The following is a description of a gene set: Genes down-regulated in splenocytes: control versus infected with Baki-1 MuLV virus. Human Gene Set: GSE24671_CTRL_VS_BAKIMULC_INFECTED_MOUSE_SPLENOCYTES_DN studied in species Homo sapiens from publication Yu P, Lübben W, Slomka H, Gebler J, Konert M, Cai C, Neubrandt L, Prazeres da Costa O, Paul S, Dehnert S, Döhne K, Thanisch M, Storsberg S, Wiegand L, Kaufmann A, Nain M, Quintanilla-Martinez L, Bettio S, Schnierle B, Kolesnikova L, Becker S, Schnare M, Bauer S (PMID 23142781) The genome of vertebrates contains endogenous retroviruses (ERVs) that have resulted from ancestral infections by exogenous retroviruses. ERVs are germline encoded, transmitted in a Mendelian fashion and account for about 8% of the human and 9.9% of the murine genome, respectively1, 2. By spontaneous activation and reintegration ERVs may cause insertional mutagenesis and thus participate in the process of malignant transformation or progression of tumor growth3, 4. However, if the innate immune system is able to recognize and control ERVs has not yet been elucidated. Here we report that, in vitro, nucleic-acid sensing TLRs on dendritic cells are activated by retroviral RNA and DNA from infected cells in vitro. Infection of TLR competent wild type mice with murine leukemia virus (MuLV)-like ERV isolates results in non-canonical gene upregulation, independent of type I IFN. In vivo, TLR3, -7 and -9 triple deficient mice (TLR379-/-) and mice with non functional TLR3, 7 and 9 signaling due to a mutation in UNC93B develop spontaneous ERV-induced viremia. More importantly, in TLR379-/- mice ERV-induced viremia correlates with acute T cell lymphoblastic leukemia (T-ALL). Multiple independent TLR379-/- T cell leukemia lines produce infectious MuLV of endogenous origin. These cell lines display de novo retroviral integration into the Nup214 or Notch1 gene locus leading to gene dysregulation that is reminiscent of aberrant Nup214 and Notch1 expression in human T-ALLs5. Overall, our results demonstrate that in addition to their role in innate immune defense against exogenous pathogens, TLR3,-7, and -9 may be essential for the control of endogenous retroviral mediated T-cell lymphomagenesis., and this is the list of marker genes: ZC3HAV1, VPS37B, TSC22D2, RPS3, TTC16, HS3ST1, SEMA4A, RPL13, PLCD1, NFKBIA, KRT19, INPP4B, KLRG1, CD69, VBP1, PRNP, AMPH, NR4A1, RPL32, GJA1, ZCCHC14, CACNB1, EPAS1 (NCBI Gene Id 2034), SIK1 (NCBI Gene Id 54018), COL5A2, THSD4, PITPNC1, DUSP6, CRYBG1 (crystallin beta-gamma domain containing 1), RBPJ, AREG, FIGNL2, ZCCHC10, FBXL21P, MYOCD (myocardin), RPS26, AFAP1L1, LPCAT2, TNFAIP3, GAR1, FSTL1, SLC18A2, CSRNP1, CALCRL, CRIP1, REEP2, MOXD1, SKIL, ATP13A3, RPS5, RMRP (RNA component of mitochondrial RNA processing endoribonuclease), FRMD4B, B4GALT4, CDKN1A, PLAC9, ZFP36L2, PPP1R15A, SLC7A8, C7, COL4A3, OTOP3, ADAMTS12, CCL1, NR3C1, KLF6, FXYD1, LIN28A, ETS2, AFF4, ATF4, NFKBID, ZFAND5, IGFBP6, CSF2, ADAM19, MMP25, CD200R1, CXCL3, PRKCQ, KCNN4, CREM, IGSF9B, IGFBP5, C11orf87, CABP5, FBLN2, GADD45B, EPRS1, ATP5F1B, MNS1, BPIFB1, PDE7B, FGL2, LAMA2, RPLP1, NAV2, DUSP1, MYO1B, FOSL2, IL17RB, NR4A2, IL2, COL1A1, SKAP1, SORBS1, LZTFL1, PTPN13, SCGB1A1, STAB2, CCR2, DCN, RPL39, CALCA, NR4A3, GLUD1, RB1, PLCG1, SAMSN1, GPC3, SEMA6D, PTPRK, SYTL1, RNF128, ITGAV, RPL36, JUNB, IRF2BP2, LMNA (lamin A/C), FAM3A, CPA3, FAM83E, IRS2 (insulin receptor substrate 2), CAST, TIE1, MT1A, EEF2, KCTD12, ICOS, FHL2, EEIG1, RPL12, PTP4A1 (protein tyrosine phosphatase 4A1), SYNE1, TMC7, ITPRID2, PITX1, FABP5P2 (NCBI Gene Id 94464), RAB4A, SYTL2, MORC4, PCSK1, SLC25A3, BCL11B, GATA3, STK17B, MYADM, TAFA3, PLEC, FLRT2, ISM1, CCRL2, PLOD2, HMGCLL1, HLF, PARD3, ZFP36L1 (ZFP36 ring finger protein like 1), NFKBIZ, S100A6, ARG1, KLF1